The following is a description of a gene set: species: Mus musculus Mouse Gene Set: REACTOME_CA_DEPENDENT_EVENTS Ca-dependent events, and this is the list of marker genes: Mapk1, Adcy4, Prkaca, Pla2g4a, Adcy9, Grk2, Adcy2, Adcy5, Adcy3, Adcy8, Prkar1a, Prkacb, Adcy6, Calm1, Prkcg, Calm2, Pde1b, Prkcd, Adcy7, Pde1c, Adcy1, Prkar1b, Camkk2, Calm3, Camkk1, Pde1a